The following is a description of a gene set: Human Gene Set: HP_SPARSE_AXILLARY_HAIR Sparse axillary hair species: Homo sapiens Reduced number or density of axillary hair., and this is the list of marker genes: AXIN2 (NCBI Gene Id 8313), GATA4, SRA1, FAT4, PSMB8, NR0B1, DHX37, LIPH, MAP3K1, DSC3, FGF17, CYP17A1, KCTD1, RPL21, DUSP6, AR, APCDD1, GNRHR, CYB5A, VAMP7, TBX3, CCBE1, NR5A1, GJB6, ITGB4, GNRH1, ZFPM2, ORC6, WT1, LHB, WWOX, FEZF1, LPAR6, CCDC141, AXL, COL17A1, SEMA3E, SRY, SPRY4, WDR11 (NCBI Gene Id 79207), TP63, HLA-DRA, FSHB, SOX9, ADAMTS3